Given this list of marker genes HMBS, PPOX, CFL2, UBA1, HNRNPA1, AGRN, HNRNPA2B1, MT-TN, SELENON, AGTPBP1 (ATP/GTP binding carboxypeptidase 1), MYH7, SUCLA2, ERBB4, TMEM43, TPM3, GLE1 (NCBI Gene Id 8012), SPG11, MTMR14, TNNT1, ACTA1, MYPN, COL6A2, CPOX, VAMP1, DES, COL25A1, TARDBP, PAX7, DYSF, COLQ, MT-TL1, COA8 (cytochrome c oxidase assembly factor 8), MB, COL6A3, ITGA7, ERGIC1, CCDC174, SLC25A4, SLC25A1, SNAP25, POLG, LMOD3, NEB, KCNJ18, GIPC1, SCN4A, ACOX1, LRP12, YARS2, TK2, RRM2B, RNASEH1, CHRNA1, SLC18A3, DYM, COL13A1, TNPO3, FHL1 (four and a half LIM domains 1), CRYAB, DOK7, CNTN1, COL12A1, SCO2, POMK, KBTBD13, MYO9A, GABRA3, MFN2, AIFM1, TRIP4, SURF1, GAA (alpha glucosidase), HACD1, GFPT1, BICD2, RYR1, DNM2, SYNE2, PLEKHG5, ORAI1, MAP3K20, LMNA, MGME1, MORC2, NOTCH2NLC, MPV17, MYL1, EMD, MYL2, SLC5A7, CHAT, HMGCR, SYT2, MYOT, MT-TL2, TTN, DMD, BIN1, KLHL41, TPI1, ALAD, MPZ, CHRNE, KCNE3, SYNE1, SMPX, SCYL2, RILPL1, VCP, CACNA1S, MATR3, COL6A1, FLNC, MYF6, ASAH1, LAMA2, TPM2, here is a description of the gene set: Weakness of muscles of respiration studied in species Homo sapiens Reduced function of the muscles required to generate subatmospheric pressure in the thoracic cavity during breathing: the diaphragm, the external intercostal and the interchondral part of the internal intercostal muscles. Human Gene Set: HP_WEAKNESS_OF_MUSCLES_OF_RESPIRATION